The following is a description of a gene set: Human Gene Set: GOBP_SEROTONERGIC_NEURON_AXON_GUIDANCE The chemotaxis process that directs the migration of an axon growth cone of a serotonergic neuron to a specific target site in response to a combination of attractive and repulsive cues. studied in species Homo sapiens, and this is the list of marker genes: VANGL2, CELSR3, PCDHAC2, WNT5A, FZD3